Given this list of marker genes Ap3b2, Ap3d1, Ap3m2, Ap3s1, Ap3s2, here is a description of the gene set: studied in species Mus musculus The formation of clathrin coated pits in the presynaptic membrane endocytic zone, triggered by the presence of high concentrations of synaptic vesicle components. This process leads to, but does not include budding of the membrane to form new vesicles. Mouse Gene Set: GOBP_SYNAPTIC_VESICLE_COATING